The following is a description of a gene set: studied in species Mus musculus The process of shaping a trabecula in the heart. A trabecula is a small, often microscopic, tissue element in the form of a small beam, strut or rod, which generally has a mechanical function. Trabecula are usually but not necessarily, composed of dense collagenous tissue. Mouse Gene Set: GOBP_HEART_TRABECULA_MORPHOGENESIS, and this is the list of marker genes: Bmpr1a, Tgfb2, Srf, Nfatc1, Dll4, Notch1, Tgfbr3, Foxh1, Fhl2, Adgrg6, Rbpj, Hey2, Smarca4, Tgfbr1, Bmp10, Ovol2, Med1, Hey1, Bmp5, Eng, Tek, Chd7 (NCBI Gene Id 57137), Heg1, Ube4b, Sos1, Fkbp1a, Egln1, Nrg1, Rbp4, Nkx2-5, Bmp7, S1pr1, Cav3, Adamts1, Nog, Ccm2l